Given this list of marker genes ARHGAP26, OPHN1, WWP2 (WW domain containing E3 ubiquitin protein ligase 2), IQGAP1, WASL, CDC42BPA, ARHGAP32, ARHGEF9, CAV1, CDC42EP3, ARHGAP21, GOPC, ARHGAP1, PREX1, VAMP3, GIT1, RHOQ, GJA1, ARHGAP17, ARHGAP33, IQGAP3, MPP7, SCRIB (NCBI Gene Id 23513), TFRC, CPNE8, TRIP10, GIT2 (NCBI Gene Id 9815), ITSN1, JUP, GFOD1, PAK4 (p21 (RAC1) activated kinase 4), SRGAP2, SYDE1, DIAPH3, ARL13B, PLEKHG3, ARHGAP35, PAK2 (NCBI Gene Id 9106), CFTR, CDC42, CDC42BPB (CDC42 binding protein kinase beta), VANGL1, SNAP23, SLC4A7, DEPDC1B, RAB7A, OBSCN (NCBI Gene Id 84033), STEAP3, STOM, LAMTOR1, ARHGAP5, FNBP1, CDC42EP4, PAK1, SLC1A5, CDC42EP1, ARHGEF7, DLC1, CDC42EP2, here is a description of the gene set: Human Gene Set: REACTOME_RHOQ_GTPASE_CYCLE species: Homo sapiens RHOQ GTPase cycle